Given this list of marker genes Slc13a3, Slc15a3, Abcb9, Slc15a2, Slc25a39, Abcc4, Abcc1, Slc15a1, Slc15a4 (NCBI Gene Id 101014), Abcb10, Slco1b2, Abcc5, Mfsd1, Gja1, Slc25a40, here is a description of the gene set: studied in species Mus musculus Enables the transfer of oligopeptides from one side of a membrane to the other. Oligopeptides are molecules that contain a small number (2 to 20) of amino-acid residues connected by peptide linkages. Mouse Gene Set: GOMF_OLIGOPEPTIDE_TRANSMEMBRANE_TRANSPORTER_ACTIVITY